Given this list of marker genes A4GALT, FUT9, VAPA, CERS4, UGT8, PRKD3 (protein kinase D3), CSNK1G2, ST8SIA6, TLCD3B, ABCC1, B3GALT1, TM9SF2, B4GALT3, PNPLA1, ABCG2, ORMDL1, ST8SIA1, ST3GAL5 (NCBI Gene Id 8869), MFSD2B, SPTLC1, ELOVL1, SMPD4, DEGS1, FUT6, LARGE1, P2RX1, ELOVL4, CYP4F22, SPTSSB, ENPP7, B3GALT2, FUT1, ST6GALNAC4 (NCBI Gene Id 27090), ELOVL2, ST8SIA4, SAMD8, ST3GAL1, ST3GAL2, ABCA2, ST3GAL3, ABCA8, ELOVL3, SGMS2, FA2H, HACD3 (3-hydroxyacyl-CoA dehydratase 3), ALOXE3, ELOVL6, SPTLC2, PRKAA1 (protein kinase AMP-activated catalytic subunit alpha 1), UGCG, SPHK1, PRKD1, PRKCD, SMPD1, ST8SIA3, KDSR, ELOVL7, SPTSSA, DEGS2, CERS3, ACER1, HACD2, FUT4, SGMS1, CERK, ELOVL5, B4GALT6, ASAH1, ORMDL2, PAQR4, CCN1, MECR, B3GALNT1, SPTLC3, ASAH2, GBA1, HACD1, ST6GALNAC5, OSBP, ZNF750, P2RX7, ST6GALNAC3, FUT2 (fucosyltransferase 2 (H blood group)), ACER3, CERKL, ST8SIA5, AGK, SPHK2, B4GALT4, ST8SIA2, B4GALNT1, A3GALT2, CERS1, ORMDL3, SIRT3, C20orf173, B3GNT5, CERS6, CLN8, SMPD2, PEMT (NCBI Gene Id 10400), ACER2, GAL3ST1, PLA2G6, ST6GALNAC6, PPM1L, B3GALT4, B4GALT5, HACD4, CERS5, ALOX12B, PRKD2, CERS2, SPNS2, here is a description of the gene set: species: Homo sapiens The chemical reactions and pathways resulting in the formation of sphingolipids, any of a class of lipids containing the long-chain amine diol sphingosine or a closely related base (a sphingoid). Human Gene Set: GOBP_SPHINGOLIPID_BIOSYNTHETIC_PROCESS